Given this list of marker genes AASS (NCBI Gene Id 10157), OTOG, CELA1, CD74, COPZ2, CHI3L1, TAF1D (NCBI Gene Id 79101), PLAC8, UBE2L6, XPNPEP2, TMEM62, PLXDC1, EZHIP, BBS7, LPL, TBXT, GTSF1, SCML2, TAF9B, CALCOCO2, CDC42EP5, STK32A, GPR137B, SLC30A3 (NCBI Gene Id 7781), ATG10, CLCNKA, KISS1, CRYBG1, DDR2, CPN1, FMR1NB, TEX19, RNF170, RBM47, CYP2J2, ACOT1, LDAF1, PCOLCE2, AOX3P, QPCT, SNCA, VWA5A, MOGAT2, CRYGD, UROC1, KLK1, ITSN1, XK, ELOVL4, TRPV2, DYNC1I1, MMP2, TTC39C, MT3, PBLD, ERICH6, MYL2, CD3D, SPINK2, AIM2, IMPDH1, ITGAE, CTSA, SELPLG, FXYD5, NIN, MSANTD5, MBL2, ACP3, MYCL, LPAR1, PRX, ADH4, SMTNL1, CYP2C18, SFTPD, SPTBN2, SULT2B1, PMEL, SPIC, MAGEA10, GPHA2, MAP1LC3A, IGBP1C (IGBP1 family member C), GREP1, KLK10, OAS1, ACTN2, KCNU1, APP, TPBG, ALOX5AP, GCA, GSTM5, FHL1, DCSTAMP (dendrocyte expressed seven transmembrane protein), FAM9C, REG1A, NTRK2, C5orf47, MDFIC, MGARP, IFI27, MANSC1, TUBA3D (NCBI Gene Id 150778), SYTL3, HECW2, SLC36A3, HOXB7, NPW, CFAP206, COX7A1, PADI6, BCAS1, HOXD8, ABCC5 (ATP binding cassette subfamily C member 5), CPNE9, PLA1A, KRT23, FAM3B, DEFA5, SLC26A4, RELN, AQP9 (NCBI Gene Id 366), CRYGS, GMPR, TNNT1, CCDC169, NCKAP1L, CABS1, BRDT, NCMAP, BRCC3, LYZL4, ANK2, C8B, RRAGD, SULT6B2P, MATCAP2 (NCBI Gene Id 23366), IFITM1, AGRP (agouti related neuropeptide), MBOAT1, IDH1, PDE6A, MX1, SAXO1, SH3RF2, SLC5A4, CCDC172, MGST2, SYCP3, TNFRSF17, HTATIP2, SLC15A2, SAPCD1, NLRP4, BEST1, RCSD1, DPYSL3, CYP2C23P, DUSP26, SLC16A9, MYL4, SLC6A13, FGL1, MINAR2, MAGEA8, FZD10-AS1, BOLL, TEX13B, KLF17, EBI3, CD200, PRICKLE1, KYAT1, FETUB, PTPN22, HSH2D, FAM25A, LY6E, H6PD, FAM9A, TSPAN2, DEFB135, SELENOP (NCBI Gene Id 6414), TST, MT1F, HLA-DQB1, KLK13, TNNI2, TMEM40, ADGRF3, TSPAN8, USP29, CDKN1A, CELA2A, SLAMF9, MAP2, DIRAS2, THY1, LGALS3BP, OC90, RNF182, HEBP2, POPDC3, CCL25, ZSCAN5B, CLPS, RIMS1, CNTNAP2, AGMAT, POF1B, ACSS1, PDLIM4, GTSF1L, BAHD1, CDH3, CXCL14, HSPB8, TEKT1, CPNE2, NRG4, TULP4, SRD5A2, COL2A1, CLIC6 (NCBI Gene Id 54102), ECHDC2, SLC4A5, GSTM3, TPH2, SASH1, MYOM3, CLCA1, MYOM2, MLLT3, DNAJC5G, ALG14, CDA, PWWP4, BPIFB5P, PNLIP, LY6G6E, HLA-DRB1, OVOL2, MFSD4B, LIPH, GPR143, PGA5, LRCOL1, SYT5, PPP2R2C, GJB4, ZC4H2, THEM5, MAGEA13P, CRABP1, RASGRP3, CCT6B, DEFB136, PKD2L1, NAT1, L3MBTL3, BFSP2, RBMS2, BARX2, here is a description of the gene set: Human Gene Set: FOSTER_KDM1A_TARGETS_UP Lysine-specific demethylase 1 (LSD1), which demethylates mono- and dimethylated histone H3-Lys4 as part of a complex including CoREST and histone deacetylases (HDACs), is essential for embryonic development in the mouse beyond embryonic day 6.5 (e6.5). To determine the role of LSD1 during this early period of embryogenesis, we have generated loss-of-function gene trap mice and conditional knockout embryonic stem (ES) cells. Analysis of postimplantation gene trap embryos revealed that LSD1 expression, and therefore function, is restricted to the epiblast. Conditional deletion of LSD1 in mouse ES cells, the in vitro counterpart of the epiblast, revealed a reduction in CoREST protein and associated HDAC activity, resulting in a global increase in histone H3-Lys56 acetylation, but not H3-Lys4 methylation. Despite this biochemical perturbation, ES cells with LSD1 deleted proliferate normally and retain stem cell characteristics. Loss of LSD1 causes the aberrant expression of genes, including those coding for transcription factors with roles in anterior/posterior patterning and limb development, such as brachyury, Hoxb7, Hoxd8, and retinoic acid receptor γ (RARγ). The gene coding for brachyury, a key regulator of mesodermal differentiation, is a direct target gene of LSD1 and is overexpressed in e6.5 Lsd1 gene trap embryos. Thus, LSD1 regulates the expression and appropriate timing of key developmental regulators, as part of the LSD1/CoREST/HDAC complex, during early embryonic development. studied in species Mus musculus from publication Foster CT, Dovey OM, Lezina L, Luo JL, Gant TW, Barlev N, Bradley A, Cowley SM (PMID 20713442) Genes up-regulated in ES cells (embryonic stem) heterozygotic for KDM1A loss of function mutant compared to the homozygotic loss of the gene.